Given this list of marker genes NFIA-AS2, MIR4300HG, GFAP, CLYBL (NCBI Gene Id 171425), FMO1, DCLK1, NKX6-1, FXYD2, CDC20B, ZIC1, PAX5, LINC02231, ZIC4, PAX2 (NCBI Gene Id 5076), LMO3, PLAAT5, SOX3, CST3, ENSG00000243620, RIMS4, SCRG1, RBM20, AQP4, LINC02935, TNC, MLC1, ALDH1L1, HMCN2, CTXND1, ADAMTS3, PAX8, GINS3, EHBP1-AS1, CLEC18B, KCNJ16, MIDEAS-AS1, WIF1, KCNMB2, TNFRSF11B, here is a description of the gene set: Marker genes curated from the annotated cluster as represented in the Descartes Human Gene Expression During Development database. from publication Cao J, O'Day DR, Pliner HA, Kingsley PD, Deng M, Daza RM, Zager MA, Aldinger KA, Blecher-Gonen R, Zhang F, Spielmann M, Palis J, Doherty D, Steemers FJ, Glass IA, Trapnell C, Shendure J (PMID 33184181) Human Gene Set: DESCARTES_FETAL_EYE_ASTROCYTES The gene expression program underlying the specification of human cell types is of fundamental interest. The study authors generated human cell atlases of gene expression and chromatin accessibility in fetal tissues. For gene expression, the study authors applied three-level combinatorial indexing to >110 samples representing 15 organs, ultimately profiling ~4 million single cells. The study authors leveraged the literature and other atlases to identify and annotate hundreds of cell types and subtypes, both within and across tissues. Our analyses focused on organ-specific specializations of broadly distributed cell types (such as blood, endothelial, and epithelial), sites of fetal erythropoiesis (which notably included the adrenal gland), and integration with mouse developmental atlases (such as conserved specification of blood cells). These data represent a rich resource for the exploration of in vivo human gene expression in diverse tissues and cell types. species: Homo sapiens